The following is a description of a gene set: Mouse Gene Set: YAO_TEMPORAL_RESPONSE_TO_PROGESTERONE_CLUSTER_5 Genes co-regulated in uterus during a time course response to progesterone: SOM cluster 5. from publication Yao MW, Lim H, Schust DJ, Choe SE, Farago A, Ding Y, Michaud S, Church GM, Maas RL (PMID 12554760) species: Mus musculus Human infertility and recurrent pregnancy loss caused by implantation defects are poorly understood. Hoxa-10-deficient female mice have severe infertility and recurrent pregnancy loss due to defective uterine implantation. Gene expression profiling experiments reveal that Hoxa-10 is an important regulator of two critical events in implantation: stromal cell proliferation and local immunosuppression. At the time of implantation, Hoxa-10 mediates the progesterone-stimulated proliferation of uterine stromal cells. Hoxa-10 mutants express a stromal cell proliferation defect that is accompanied by quantitative or spatial alterations in the expression of two cyclin-dependent kinase inhibitor genes, p57 and p15. Hoxa-10 deficiency also leads to a severe local immunological disturbance, characterized by a polyclonal proliferation of T cells, that occurs in place of the normal progesterone-mediated immunosuppression in the periimplantation uterus., and this is the list of marker genes: Klf10, Col15a1, Wwc1, Klk1b2-ps, Atf3, Bpifa2, Pck1, Isg20, Reln, Hspa1a, Cx3cl1, S100g, Pptc7, Col5a2, Adm, Kcnq1, Ier3, Lcn2 (lipocalin 2), Msrb1, Bex1, Gap43, Vegfa, Cyp2e1, Il18r1, Hoxa11os (homeobox A11, opposite strand), Basp1, Cndp2, Ndufb2, Usp2, Per1, Xdh, Klf4